Given this list of marker genes SUCLG1, ACSL1, ACSM3, ACSS2, ACSM2B, SLC27A2, SUCLG2, ACSL5, ACSL4, ACSL6, ACSL3, SLC27A5, ACSM1, ACSBG1, ACSM2A, SLC27A1 (NCBI Gene Id 376497), AASDH, SLC27A6, ACSF3, ACSM5, SLC27A3, ACSM4, DIP2A, SUCLA2 (succinate-CoA ligase ADP-forming subunit beta), ACSS1 (NCBI Gene Id 89850), AACS, ACSF2, ACSS3, ACSBG2, ACSM6, SLC27A4 (solute carrier family 27 member 4), here is a description of the gene set: species: Homo sapiens Human Gene Set: GOMF_ACID_THIOL_LIGASE_ACTIVITY Catalysis of the joining of an acid and a thiol via a carbon-sulfur bond, with the concomitant hydrolysis of the diphosphate bond in ATP or a similar triphosphate.